Given this list of marker genes Dio2, Cga, Duoxa2, Cav1, Duoxa1 (dual oxidase maturation factor 1), Duox1, Iyd, Tpo, Dio1, here is a description of the gene set: part of: Metabolism of amine-derived hormones Reactome Pathway: Thyroxine biosynthesis electronically inferred by orthology from the curated human pathway This event has been computationally inferred from an event that has been demonstrated in another species.<p>The inference is based on the homology mapping from PANTHER. Briefly, reactions for which all involved PhysicalEntities (in input, output and catalyst) have a mapped orthologue/paralogue (for complexes at least 75% of components must have a mapping) are inferred to the other species. studied in species Mus musculus